Given this list of marker genes Lyg1, Pglyrp1, Pglyrp4 (peptidoglycan recognition protein 4), Pglyrp3, Lyg2, Pglyrp2, here is a description of the gene set: species: Mus musculus The chemical reactions and pathways involving peptidoglycans, any of a class of glycoconjugates found only in bacterial cell walls and consisting of long glycan strands of alternating residues of beta-(1,4) linked N-acetylglucosamine and N-acetylmuramic acid, cross-linked by short peptides. Mouse Gene Set: GOBP_PEPTIDOGLYCAN_METABOLIC_PROCESS